The following is a description of a gene set: Mouse Gene Set: GOBP_REGULATION_OF_VACUOLE_ORGANIZATION studied in species Mus musculus Any process that modulates the frequency, rate or extent of a process involved in the formation, arrangement of constituent parts, or disassembly of a vacuole., and this is the list of marker genes: Sec22b, Trim32, Grn, Pip4k2b, Mtm1, C9orf72, Tbc1d12, Laptm4b, Moap1, Snx7, Smcr8, Lrsam1, Atg2a (NCBI Gene Id 69041), Sh3glb1, Elapor1, Tmem106b, Ift20, Nupr1, Pikfyve, Ift88, Ephb2, Phf23, Pip4k2a, Tbc1d14, Pip4k2c, Ralb, Anxa2, Irgm2, Ehmt2, Rab3gap1, Igtp, Fez1, Flcn, Rnf186, Mcoln1, Trex1, Ubqln2, Snx30, Efnb1 (ephrin B1), Mtor, Wipi1, Chek2 (NCBI Gene Id 50883), Lrrk2, Snx18, Irgm1, Becn1, Tmem39a, Scfd1, Rab1b, Pink1, Rnf5, Fez2, Snx4, Rab3gap2, Ulk1, Ppp3cb, Wdr45, Fnip1, Mtmr3